The following is a description of a gene set: studied in species Mus musculus from publication Howe DG, Blake JA, Bradford YM, Bult CJ, Calvi BR, Engel SR, Kadin JA, Kaufman TC, Kishore R, Laulederkind SJF, Lewis SE, Moxon SAT, Richardson JE, Smith C (PMID 30224793) Mouse genes annotated to HALLMARK_P53_PATHWAY based on orthology mappings provided by the Alliance Genome Consortium Mouse Gene Set: HALLMARK_P53_PATHWAY, and this is the list of marker genes: Rap2b, F2r, Tm7sf3, Sertad3, Vamp8, Rgs16, Ldhb, Plk2, Btg2, Sec61a1, Procr, Cyfip2, Fbxw7, Ralgds, Plk3, Tob1, Slc7a11, Phlda3, Irak1, Vwa5a, Vdr, Trp63, Atf3, Trib3, Zfp365, Tgfb1, Upp1, Ifi30, Ptpre, Cdkn1a, Zfp36l1, Ccnd3, Ephx1 (NCBI Gene Id 98277), Krt17, Ccnk, Slc19a2, Dram1, Hexim1, Irag2, H1f2, Rpl36, Foxo3, Cdkn2a, Perp, St14, Nupr1, Dnttip2, Cd81, Tprkb, Bmp2, Rb1, Rack1 (NCBI Gene Id 14694), Hbegf, Rxra, Clca2, Rps27l, Nhlh2, Ccnd2, Sdc1, Ctsd, Bak1, Gpx2, Hint1, Gadd45a, Mapkapk3, Tm4sf1, Zbtb16, Ier5, S100a4, Sat1, Eps8l2 (EPS8-like 2), Fas, Gm2a, Ccng1, Fgf13, Cdh13, Ankra2, Mxd1, Lif, Tspyl2, Mxd4, Kif13b, Def6 (NCBI Gene Id 69722), Fos, Ddb2, Abcc5, Jun, Stom, Ier3, H2ac25, Rab40c, Cebpa, Polh, Baiap2, Gls2, Socs1, Tpd52l1, Ddit4, Rps12, Traf4, Trafd1, Tnni1, Slc3a2, Apaf1, Cdkn2b, Retsat, Sesn1, Coq8a, Pom121, Rrad, Elp1, Tax1bp3, Trp53, Ercc5, Fdxr, Csrnp2, Hdac3, Il1a, Btg1, Cdk5r1, Aen, Tgfa, Hras, Ptpn14 (protein tyrosine phosphatase, non-receptor type 14), Rpl18, Rnf19b, Bax, Acvr1b, Inhbb, Ccp110, Tap1, Klk8, Fam162a, Pitpnc1, Wwp1, Tcn2, Hmox1, Cdkn2aip, Triap1, Hspa4l, Cd82, Ndrg1 (NCBI Gene Id 17990), Dcxr, Abhd4, Dgka, Mknk2, Rrp8 (ribosomal RNA processing 8), Ei24, Ninj1, Fuca1, Prkab1, Steap3, Mdm2, Slc35d1 (NCBI Gene Id 242585), Rhbdf2 (rhomboid 5 homolog 2), Ak1, Cgrrf1, Rchy1, Alox8, Pvt1, Pidd1, Ip6k2, Ada (NCBI Gene Id 11486), Epha2, Klf4, Itgb4, Jag2, Ppp1r15a, Ctsf, Plxnb2, Ppm1d, Sphk1, App, Rad9a, Nudt15, Ddit3, Zmat3, Tsc22d1, Xpc, H2aj, Prmt2, Iscu (iron-sulfur cluster assembly enzyme), Tchh, Tnfsf9, S100a10, Sp1, Osgin1, Sfn, Pcna, Pdgfa, Rad51c, Blcap, Wrap73, Casp1, Pmm1, Notch1, Nol8, Abat, Serpinb5, Txnip